Given this list of marker genes KIT, TNPO3, IL12RB1, POU2AF1, CARMIL2, ADGRE2, SUPT16H, SERPING1, IRF5, SLC27A4, PLCG2, MMEL1, SPIB, TNFSF15, IL12A, here is a description of the gene set: Urticaria caused by physical agents, such as heat, cold, light, friction. studied in species Homo sapiens Human Gene Set: HP_PHYSICAL_URTICARIA Physical urticaria